Given this list of marker genes FAM83F, CCDC71L, PITPNM2, SPTLC2, GK2, SLC39A8, MPP1, TBK1, HSPA1B, ATAD2B, PPP1R2P1, ATL3 (atlastin GTPase 3), SAA4, PI4K2A, CD70, ELOC, ZDHHC5, FUT7, CAMK2A, SLC6A13, MT4, RNF2, DYNC1I1, CRBN, ECE2, IQGAP1, TCF4, TJAP1, CHIC2, IL18, C19orf12, TOR3A, NFKB1, GRB7, PMPCB, MEP1B, KRT33B, FABP9, CSDE1, RBM43, LHX6, EGFR, MGAT5, ZBP1, SLC5A11, APBB2, WWC2, METAP1, MARCO, FAAH, NOS2, WSB2, UBE2D1, PLXNB3, TRAF5, TNF (NCBI Gene Id 7124), ZFP62, CYSTM1, TCF25, HOXC13, PPP1R15A, F3, BMPR1A, UBE2J1, TANC1, GBP2, SERPINB9 (serpin family B member 9), INSM1, GK, MACROD2, FGF22 (fibroblast growth factor 22), NAMPT, SLC44A1, GNA13, CACYBP, IL10RB, LIF, PRKG2, GINM1, ELL2, METTL6, PRKAR1B, MCMBP, RGL1, FNBP4, CHRNA5, BATF (basic leucine zipper ATF-like transcription factor), OLR1, KATNBL1, RPE, PARP14, FRMD6, SLC30A3, ETS2, TRMT1L, SEPTIN2, IRGM, GYPC, GLIPR1L2 (GLIPR1 like 2), ESR1, HP1BP3, MYF5, CCNJ, STK40, PLEKHF2, APBB1IP, LY96, BMX, ABI1, GRHL2 (grainyhead like transcription factor 2), HK2, ARHGAP17, TPR, LAMB3, NEAT1, IL36RN, STARD5, GDNF (glial cell derived neurotrophic factor), PLEKHA5, CCDC65, CCL13, ATP6V1E1, TRIM25, SEMA4G, CXCL6, DUSP16, POLR2C, RSPO1, CREBRF, TRA2B, TRIM26, HRH3, GAPDHS, KLHL13, IL23A, PIKFYVE, BIRC3, PON3, PPP1CB, ORM1, HINFP, M1AP, UBAP1, SERPINE1, LMO4 (LIM domain only 4), ARTN, STAU1, DBR1, STXBP3, LZTFL1, PROCR, MOSPD2, ATM, KEAP1, SIX1, TMEM79, ACRBP, RUNX2, FAM107B, PTPRE, LOXL1, GCA, DNM3, STXBP1, ACTN1, UBE2E1, RAB32 (NCBI Gene Id 10981), RNF34 (NCBI Gene Id 96268), AP1G1 (NCBI Gene Id 164), EBI3, PI15, HBG2, KHDC4, CWC15, SLC9A8, STAT5A, RBM47, GRP (NCBI Gene Id 2922), CHTF8, RILPL1, BCL11B, UPK3B, ICOS, STAT2, UPF2, ELAVL4, VCL (NCBI Gene Id 7414), MMP14, TIMP1 (NCBI Gene Id 7076), SOCS1, PALLD, ITGB1, TMA16, CAVIN3, SAPCD1, ZNF189, UNK, RAB10, FAM241B, PMFBP1, here is a description of the gene set: Human Gene Set: GSE17721_0.5H_VS_4H_LPS_BMDC_DN from publication Amit I, Garber M, Chevrier N, Leite AP, Donner Y, Eisenhaure T, Guttman M, Grenier JK, Li W, Zuk O, Schubert LA, Birditt B, Shay T, Goren A, Zhang X, Smith Z, Deering R, McDonald RC, Cabili M, Bernstein BE, Rinn JL, Meissner A, Root DE, Hacohen N, Regev A (PMID 19729616) Genes down-regulated in comparison of dendritic cells (DC) stimulated with LPS (TLR4 agonist) at 0.5 h versus those stimulated at 4 h. species: Homo sapiens mouse primary BMDCs were stimulated with tlr ligands and gene expression changes were profiled on Affymetrix arrays